The following is a description of a gene set: Genes predicted to be targets of miRBase v22 microRNA hsa-miR-1275 in miRDB v6.0 with MirTarget v4 prediction scores > 80 (high confidence targets). from publication Chen Y, Wang X (PMID 31504780) studied in species Homo sapiens Human Gene Set: MIR1275, and this is the list of marker genes: SDCBP2, LRRC28, SNX29, SUCNR1 (NCBI Gene Id 56670), SYNPR, ZNF629, ELFN2, ZSWIM4, ACLY, CAMK1D, PCDHGA12, UBE2Z, RDX, NXPH2, SERTAD2, ZNF823, PCDHGA3, EXOC6B, VPS37D, PCDHGB7, KRT23, SDC3, PTGER3, IGF2BP3, TSPAN11, TACR1, CITED4, KCTD20, PCDHGC3, IGF1R, TBC1D15, SERPINE2, COL1A1, ATP10B, ISL1, CBX6, NSD1, CASTOR2, STIM1, DDA1, NFIX, NAALADL2 (NCBI Gene Id 254827), CTNND2, NOS1 (NCBI Gene Id 4842), ZNF131, BHLHE41, TNNI1, CEBPG, IP6K3, GNAT1, CLEC12B, SDHAF1, APLN, TTC14, CFAP418, CALCOCO1, SSR1, ARRB1, SLC25A42, DDX17, CBLN1, CDK18, FOXP2, LEFTY2, FILIP1L, PPT2, TMTC2, NBN, SETBP1, SH2B1, NKAPL, MTMR4, GANAB, SENP6, ZDHHC15, AKNAD1, SPTAN1, MKNK2, ZFP14, HMGB3, RABGGTB, POU4F1, SNTB1, HMGA1, CCDC184, PCDHGA4, SIAH2, PCDHGB4, RSPO2, ASB11, ANGPTL3, SSX2IP, HMGXB3, C12orf75, PCDHGB1, PRKCA, DIRAS2, TM9SF2, DVL3, MFN2, G3BP2, PCDHGA6, PCDHB13, ZNF32, SPOCK1, TMEM63B, CA10, ABCF1, TCEANC2, SLAMF8, GPATCH2L, GRIK2, PCDHGA10, PCDHGB3, CASP14, NFIC (nuclear factor I C), APLNR, UNC13A, JAZF1, WDHD1, SHISA7, SLC45A3, SPRED3, RAD52, PRKACA, SPINT1, IGF2, GATAD2B, SLC30A7, OVOL2, NOVA2, SPEN, PCDHGB2, NUAK1, ADAR, CNTNAP1, ELOVL2, GIMAP1, VAMP2, KCNV1, RAB11FIP5, ELK1, CACNA1D, PPM1E, SOX7, FSTL1, TRPC4AP, PCDHGA5, CLEC2D, CCDC33, PKNOX2, OTOR, CTBS, MGST2, SAMD4B, IGF2BP1, DCLK1, KCNJ10, TMIGD2, MAPK4, TTC39C, RNF10, PCDHGA2, FBN1, SIAH1, NFASC, CYP2C19, EMILIN3, COPG1, PCDHGA7, PTPRO, SPA17, CACNA1E, TMEM38B, FOXP4, ACTB, LALBA (NCBI Gene Id 3906), TTC17, P2RX7, SCRT2, PLGLB2, ELOB, PTGIS, PALM2AKAP2, MAP1A, SHISAL1, MYCT1, POU3F2, SRGAP1, PCDHGA9, PAX5, SLC7A8, TSKU, NAPA, MTHFR, RAB3B, GPANK1, PCDHGC5, ZNF444, CCDC148, PCDHGA11, PIGG, HNRNPAB, ADGRG6, PCDHGB6, SPIDR, PRR12, LIMK1, DUSP8, NALF2, PCDHB11, PINX1, PCDHGB5, ZFP36L2, DEF8, SEC24A, TLNRD1, PHYH, RBMX, NECTIN1, MECP2, IGF1, ATCAY, CLDN11, CADM4, RAB3A, FTO, WASHC4, BAHCC1, WIZ, PCDHGA8, LPCAT3, CD8B, AP1G1, LAPTM4B, PPP2R2D, GUCA1B, KLHL28, REG3A, ZBTB33, STS, SIRT2, PCDHGC4, STX8, INHBC, MPZ, RPAIN, UBTF, VPS37B, ENY2, MAJIN, UPK2, EXOG, MPZL2, YIPF6, CACNA1I, BRWD3, PPP1R3C, SPICE1, TCP11L1, WDFY1, PCDHGA1, FAM50B, ASB4, PKM, CASKIN2, SPAG9, SLC2A4RG, VDAC2 (voltage dependent anion channel 2), SLC10A2 (NCBI Gene Id 6555), SSC4D, THUMPD2, SYT7, PRPH2, LZTS3, PLP1, KSR2, PLGLB1, SLC39A3, GPR3, FOXA3, CACNA1C, CPSF7, MXD1, ZBTB7A, SLC6A17, IL13RA1